The following is a description of a gene set: The phototransduction cascade Mouse Gene Set: REACTOME_THE_PHOTOTRANSDUCTION_CASCADE studied in species Mus musculus, and this is the list of marker genes: Gngt1, Nmt1, Nmt2, Grk4, Calm2, Rho, Rgs9bp, Pde6g, Rcvrn, Metap1, Grk1, Sag, Metap2, Cngb1, Cnga1, Pde6b, Camkmt, Fnta, Calm1, Fntb, Calm3, Gnb5, Rgs9, Guca1a, Gucy2f, Ppef1, Guca1b, Gnat1, Gucy2e, Gnb1 (NCBI Gene Id 99986)